Given this list of marker genes DEDD, CAPRIN1, TPST2, GLRA2, RMDN1 (NCBI Gene Id 51115), ZC3H11C, UBQLN1, here is a description of the gene set: Human Gene Set: MIR8053 Genes predicted to be targets of miRBase v22 microRNA hsa-miR-8053 in miRDB v6.0 with MirTarget v4 prediction scores > 80 (high confidence targets). from publication Chen Y, Wang X (PMID 31504780) species: Homo sapiens